The following is a description of a gene set: A host’s normal protective response to tissue injury or pathogenic infection is acute inflammation. The condition of acute inflammation is created by the release of pro-inflammatory lipid mediators such as leukotrienes (LTs) and prostaglandins (PGs) that launch a series of signaling cascades to destroy invading pathogens and to repair damaged tissue. The potent chemotactic agent leukotriene B4 (LTB4) promotes the recruitment of neutrophils (PMNs) to inflamed tissues, while the prostaglandins E2 and D2 (PGE2 and PGD2) further accelerate the inflammatory process. If left unchecked, the inflammatory response can initiate chronic systemic inflammatory disorders associated with cardiovascular disease, rheumatoid arthritis, periodontal disease, asthma, diabetes, inflammatory bowel disease (IBD), Alzheimer’s disease and age-related macular degeneration (AMD). The specific role by which inflammation contributes to their pathogenesis is not fully understood.<br><br>To prevent the onset of chronic inflammation, a <i>lipid mediator class switch</i> is thought to occur from the initial actions of pro-inflammatory lipid mediators to the anti-inflammatory and pro-resolving actions of lipoxins, resolvins, protectins and maresins (collectively called specialized proresolving mediators (SPMs)). Nanopicogram quantities of different lipid mediators are generated at different times during the evolution of the inflammatory response and these mediators coincide with distinct cellular events. The class switch activates leukocyte translational regulation of the enzymes required to produce pro-resolving lipid mediators. Each family of these PSMs exert specialized actions, including blocking neutrophil recruitment, promoting the recruitment and activation of monocytes, as well as mediating the nonphlogistic phagocytosis and lymphatic clearance of apoptotic neutrophils by activated macrophages (ie without inducing inflammation) and mediating tissue regeneration. Eventually, through the combined actions of these mediators, the resolution of inflammation is completed and homeostasis is reached.<br><br>SPMs are derived from polyunsaturated fatty acids (PUFAs). PUFAs of the ω-3 series are essential nutrients since they cannot be produced by humans (Duvall & Levy 2016) and are primarily found in dietary fish oils and in plants. The ω-3 PUFAs eicosapentaenoic acid (EPA), docosahexaenoic acid (DHA) and docosapentaenoic acid (DPAn-3) circulate in the bloodstream after dietary intake and are easily incorporated into cellular membranes in a time- and dose-dependent manner, as well as being present in inflammatory exudates. They can be mobilised by phospholipase A2 from cellular membranes on injury or infection when they are converted to exudate SPMs to interact with local immune cells. EPA is the source for E-series resolvins while DHA is the source for D-series resolvins, protectins, maresins and sulfido conjugates in tissue regeneration mediators. The ω-6 fatty acid arachidonic acid (AA) is the source for lipoxins. ω-3 or ω-6 PUFA docosapentaenoic acids (DPAn-3 and DPAn-6) are the sources of DPA-derived resolvins, protectins and maresins. Aspirin can also trigger the production of epimeric SPMs via acetylated PTGS2 (prostaglandin G/H synthase, COX2) (Serhan & Chiang 2002). Combinations of oxidation, reduction and hydrolysis can generate numerous SPMs. Electrophilic oxo-derivatives of ω-3 PUFAs are a class of oxidised derivatives that are generated in macrophages and neutrophils by the actions of 5-lipoxygenase, cyclooxygenase-2 and acetylated cyclooxygenase-2, followed by dehydrogenation. Being electrophilic, oxo-derivative SPMs reversibly bind to nucleophilic residues on target proteins, triggering the activation of cytoprotective pathways. The pathways in this section describe the biosynthesis of these SPMs. part of: Metabolism of lipids Reactome Pathway: Biosynthesis of specialized proresolving mediators (SPMs) studied in species Homo sapiens, and this is the list of marker genes: ALOX12, CYP2C8, CYP2D6, LTA4H, CYP1A2, CYP2E1, LTC4S, ALOX5AP, CYP1A1, PTGR1, GPX4, ALOX5, ALOX15, CYP2C9, PTGS2, EPHX2, GSTM4, HPGD, CYP3A4